Given this list of marker genes STX18, RBBP8NL, C19orf48P, KBTBD6, USPL1, MCF2L2, TMPRSS11F, GNPTG (N-acetylglucosamine-1-phosphate transferase subunit gamma), SLC44A1, HARBI1, MTCO3P12, TVP23B, KAT6A, NSFL1C, LINC01596, MT-TC, KANSL1, RPL26L1, LINC00536, COX16, TUBGCP3, KDM5A, SMARCD2, INTS5, NCBP2, WEE2-AS1, TMEM79, ESRP2, DPY19L4, ZER1, ENSG00000232995, NT5C2, KBTBD11-OT1, MIR203A, RPL37, PCYT1A, MAN2C1, AAAS, POLR2J3, NOP16, TFPT (TCF3 fusion partner), SYT7, MIR1302-3 (NCBI Gene Id 100302128), NKAP, ALDH3B2, SUGCT (NCBI Gene Id 79783), NOXA1, BAP1 (BRCA1 associated deubiquitinase 1), KMT2A (lysine methyltransferase 2A), DUX4L18, DUSP1, LRRC37A3, GARS1 (NCBI Gene Id 7972), MT-ND4L, SSBP1, WDR31, NSL1, ATG13 (autophagy related 13), ALG10B, MAPDA, CIPC, ARHGEF12, CRACDL, LSG1, CAMTA2, SIRT4, MICAL3, LINC01975, SMG5, P4HB, DDX11, WDR11, SLC39A3, HIRA, HMGB1, KCTD10, WDR11-DT, ENSG00000233017, NDUFS7 (NADH:ubiquinone oxidoreductase core subunit S7), MTOR, SLC35B1, TNRC18, MPLKIP, SNORA21, STX18-AS1, RNU7-27P, GARS1-DT, ATP2B4, STX16, KAT2A, MT-ND6, TSR3, GRHL2-DT, RBM28, CSNK1G2, ATPAF1, DCP1A, MKRN2, NOP10, FYCO1, UTP3, TMC1, ZDHHC6, CDK11A, TIMM9, NEK9, ADNP, GRHL2 (NCBI Gene Id 79977), ZMPSTE24 (zinc metallopeptidase STE24), NUDT5, SNRNP35 (small nuclear ribonucleoprotein U11/U12 subunit 35), MT-TT, TBL3, RTKN2, DDX11-AS1, ENSG00000265246, SSBP2, CDH26, CLASP1, UBE3B, VPS51, VTI1A, FUT10, LRP6, RNU4ATAC, ISY1, RBBP5, EXOSC8, STX16-NPEPL1, TEX38, HUNK-AS1, CLDN4, NCBP2AS2, BRWD1, B4GALT7, TMEM242-DT, PRPF31, TATDN3, LMNB1, NUF2, KIAA0586, TPRG1-AS1, CYP3A43, MT-CYB, DHX8, MT-TE, PRKCD, MT-TY, VARS2, SNRPD1 (NCBI Gene Id 6632), RGS5, MT-TN, ALG5, MT-TR, CDC123, MT-TG, KBTBD6-DT, FAM230G, SLC45A4 (NCBI Gene Id 57210), TARS2, NDUFS3, ZNF554, MTF2, RPL26L1-AS1, MT-TA (mitochondrially encoded tRNA-Ala (GCN)), LINC02408, RBBP8, SMG8, PHF7, IPO4, PLCB1, EIF2D, RPL23 (NCBI Gene Id 9349), ELFN1-AS1, EXD3, ADAP1, MRPS31, NCBP3, KBTBD4, SFSWAP, PKM, ZMPSTE24-DT, SLC33A1, LMAN2, CENPU (NCBI Gene Id 79682), MT-ND4, MRPL40, ISY1-RAB43, GBA1, ADPRHL1, KCTD5, LMNB1-DT, UQCC6, GTF2H4, CDR2L, GLMP, RPL32P30, MT-ND3, TOR1AIP1, TMEM242 (NCBI Gene Id 729515), HSPB9, TDRD7 (tudor domain containing 7), NUTM1, RHPN2, here is a description of the gene set: species: Homo sapiens Human Gene Set: WDHD1_TARGET_GENES from publication Yevshin I, Sharipov R, Kolmykov S, Kondrakhin Y, Kolpakov F (PMID 30445619) Genes containing one or more binding sites for (WDHD1) in their promoter regions (TSS -1000,+100 bp) as identified by GTRD version 20.06 ChIP-seq harmonization.